Given this list of marker genes SLC39A8, OAT, ASL, NOS2, CLN3, SLC7A7, ATP2B4, MIR21, ARG2, DDAH1, NOS3, AZIN2, NOS1, AGMAT, ODC1, ARG1 (NCBI Gene Id 383), ART4, NAGS, FAH, AZIN1, FH, ASS1, OTC, here is a description of the gene set: The chemical reactions and pathways involving arginine, 2-amino-5-(carbamimidamido)pentanoic acid. studied in species Homo sapiens Human Gene Set: GOBP_ARGININE_METABOLIC_PROCESS